Given this list of marker genes PRR12, PRPH2, ITPR1, COL18A1, LYST, PROM1, AP3D1, HPS5, HPS6, GPR143, ATF6, CACNA1F, BLOC1S5, FZD4, SLC45A2, MAF, GDF3, ATOH7, SLC25A19, UGP2, BLOC1S3, DCT, ABCA4 (NCBI Gene Id 7815), MYO5A, OCA2, CFAP418, PDE6H, NDP, MTSS2, HMX1, MPDZ, POMGNT1, FOXC1, GNAT2, TYR, DPYD, EBP, ELOVL4, GDF6, MC1R, CNGA3, LAMB2, EPG5, HPS4 (HPS4 biogenesis of lysosomal organelles complex 3 subunit 2), NEU1, PAX6, WT1, PDE6C, CNGB3, SLC38A8, FZD5, RPGR, TRIM44, SLC24A5, IKBKG, here is a description of the gene set: Human Gene Set: HP_APLASIA_HYPOPLASIA_OF_THE_RETINA species: Homo sapiens Aplasia/Hypoplasia of the retina